The following is a description of a gene set: Human Gene Set: GSE21927_UNTREATED_VS_GMCSF_IL6_TREATED_BONE_MARROW_UP Tumor growth is associated with a profound alteration of myelopoiesis, leading to recruitment of immunosuppressive cells known as myeloid-derived suppressor cells (MDSCs). Analyzing the cytokines affecting myelo-monocytic differentiation produced by various experimental tumors, we found that GM-CSF, G-CSF, and IL-6 allowed a rapid generation of MDSCs from precursors present in mouse and human bone marrow (BM). BM-MDSCs induced by GM-CSF+IL-6 possessed the highest tolerogenic activity, as revealed by the ability to impair the priming of IFN- -producing CD8+ T cells upon in vivo adoptive transfer. Moreover, adoptive transfer of syngeneic, GM-CSF+IL-6-conditioned MDSCs to diabetic mice transplanted with allogeneic pancreatic islets resulted in long term acceptance of the allograft and correction of the diabetic status. Cytokines inducing MDSCs acted on a common molecular pathway. Immunoregulatory activity of both tumor-induced and BM-derived MDSCs was entirely dependent on C/EBP transcription factor, a key component of the emergency myelopoiesis triggered by stress and inflammation. Adoptive transfer of tumor antigen-specific CD8+ T lymphocytes resulted in therapy of established tumors only in mice lacking C/EBP in myeloid compartment. These data unveil another link between inflammation and cancer and identify a novel molecular target to control tumor-induced immune suppression. We used gene expression analysis to identify those factors, secreted by tumor-infiltrating MDSC, which could drive emathopoiesis. Moreover we compare gene expression profile of tumor-induced MDSC, obtained from either the spleen and the tumor infiltrate of tumor bearing mice, and in vitro bone marrow-derived MDSC. from publication Marigo I, Bosio E, Solito S, Mesa C, Fernandez A, Dolcetti L, Ugel S, Sonda N, Bicciato S, Falisi E, Calabrese F, Basso G, Zanovello P, Cozzi E, Mandruzzato S, Bronte V (PMID 20605485) studied in species Homo sapiens Genes up-regulated in CD11b BoneMarrow from BALBc mouse versus CD11b BoneMarrow from BALBc mouse incubated with GMCSF and IL-6., and this is the list of marker genes: APCDD1L, MMP2, H2AC25, MAPK6, VPS53, CNOT11 (NCBI Gene Id 55571), MIR100HG, IRGM, TMEM69, TSNARE1, PCOTH, PACSIN3, KCNJ2-AS1, TCEAL1, ENSG00000269155, DIO3OS, HERPUD2, TMEM168, RUNDC3B (RUN domain containing 3B), GFRA2, TLE3 (TLE family member 3, transcriptional corepressor), ST7-AS1, ZNF875, RPRML, DDO, TMEM175, HP1BP3, GPIHBP1, ZNF585B, TPT1-AS1 (NCBI Gene Id 100190939), ZNF138, LINC00334, UBA6, MFSD5, HOTAIR, PAMR1, THOC7, INO80, OGFRL1 (NCBI Gene Id 79627), TGM6, CPA2, TIMM23, ARID3B, CBX8, TRAPPC2, RALB, ADNP2, KIF20B, TFDP2, SLITRK1, PRR19, ATXN7L3B, ILF3, ARHGEF3, RANBP6, RAMAC, TMTC1 (NCBI Gene Id 83857), CHCT1, ERLIN2, UBL3, ZBED1, YWHAZ, ATF2, RNF220, TGIF2LY, RPE65, NEK11, RBM12B, OR8B8, SLC38A3, ZBTB26, MTPAP, CD72, PPM1G, SLC12A8, HSDL2, MNDA, PRR13, CRIP2, SH3BGRL2, BEX2, DNAL1, SDC1, NDUFB5, FKBP5, CAPN2, ANAPC16, SLC1A5, FHL2, MAP2, STARD7-AS1, CABP2, ADTRP, MTFR1L, ETS1, EPM2A, ACSF3, LINC02003, FAM120AOS, CCL26, WIF1, CSGALNACT2, TMEM68, ANKRD6 (ankyrin repeat domain 6), UBXN2B, C22orf39, IKBKB, UCHL1, GMFG, ARMCX5, EPS15, SLC35B2, MROH9, HOATZ, VDAC2, RAD51AP1, BICRA, JRKL, GLUL, HNRNPA3P1, TRAM1L1, LINC01003 (long intergenic non-protein coding RNA 1003), KRT35, CAND1, TMEM216, SPAG17, S100A8, TEAD3, OTOR, SCAMP2, MRM2, SRSF6, PPP1R12A, YPEL2, PITPNA-AS1 (PITPNA antisense RNA 1), RAB11B, WNT8B, MACF1, HDGF, MTCL1, MTCH2 (NCBI Gene Id 23788), RIPOR1, ARHGAP5-AS1, PPP1R14C, MLNR, MEX3A, RNF24, CTDSP2, FAM124A, COX15, LINC01097, GAS2L3 (NCBI Gene Id 283431), LSM11, ZNF350, PLGRKT, BRIP1, AVEN, AACSP1, LIMS1, CFAP53, TNFSF13, SNORD89, SCUBE1, FOXO4, LRRC25, DDX53, HOXA13, PON2, ZNF33B, MYSM1, ARL16 (NCBI Gene Id 339231), MAMLD1, PRKCA, IMMP2L, FAM89B, PRELID1, TNKS1BP1, NCBP3, RIOX1, LINC01931, RNF135, RNF152 (ring finger protein 152), ADGRE2, RPS6KA5, ETNPPL, ALAS1, GPC6, KBTBD2, ZNF85, C17orf58, ENSG00000291065, OGA, ZNF17, PCDH18